Given this list of marker genes Adcy1, Adcy7, Adcy3, Adcy6, Gnai1, Calm2, Adcy8, Adcy9, Adcy10, Gucy1a1, Calm1, Raf1, Gnas, Rgs2, Grm7, Adcy4, Gnaz, Calm3, Adcy2, Gucy1b1, Adcy5, Adgrv1, here is a description of the gene set: Catalysis of the reaction: ATP = 3',5'-cyclic AMP + diphosphate. studied in species Mus musculus Mouse Gene Set: GOMF_ADENYLATE_CYCLASE_ACTIVITY